Given this list of marker genes TAP1, STAT1, ANKRD22, GBP4, GBP1, WARS1, PSME2, CXCL9, AIM2, GBP5, here is a description of the gene set: studied in species Homo sapiens Human Gene Set: MATSUMIYA_PBMC_MODIFIED_VACCINIA_ANKARA_VACCINE_AGE_4_6MO_BCG_PRIMED_28DY_UP BACKGROUND: Tuberculosis (TB) remains a global health problem, with vaccination likely to be a necessary part of a successful control strategy. Results of the first Phase 2b efficacy trial of a candidate vaccine, MVA85A, evaluated in BCG-vaccinated infants were published last year. Although no improvement in efficacy above BCG alone was seen, cryopreserved samples from this trial provide an opportunity to study the immune response to vaccination in this population. METHODS: We investigated blood samples taken before vaccination (baseline) and one and 28 days post-vaccination with MVA85A or placebo (Candin). The IFN-gamma ELISpot assay was performed at baseline and on day 28 to quantify the adaptive response to Ag85A peptides. Gene expression analysis was performed at all three timepoints to identify early gene signatures predictive of the magnitude of the subsequent adaptive T cell response using the significance analysis of microarrays (SAM) statistical package and gene set enrichment analysis. RESULTS: One day post-MVA85A, there is an induction of inflammatory pathways compared to placebo samples. Modules associated with myeloid cells and inflammation pre- and one day post-MVA85A correlate with a higher IFN-gamma ELISpot response post-vaccination. By contrast, previous work done in UK adults shows early inflammation in this population is not associated with a strong T cell response but that induction of regulatory pathways inversely correlates with the magnitude of the T cell response. This may be indicative of important mechanistic differences in how T cell responses develop in these two populations following vaccination with MVA85A. CONCLUSION: The results suggest the capacity of MVA85A to induce a strong innate response is key to the initiation of an adaptive immune response in South African infants but induction of regulatory pathways may be more important in UK adults. Understanding differences in immune response to vaccination between populations is likely to be an important aspect of developing successful vaccines and vaccination strategies. TRIAL: ClinicalTrials.gov number NCT00953927. Genes up-regulated in peripheral blood mononuclear cell 28d vs 7d in infants (4-6m) (BCG-primed) after exposure to Modified Vaccinia Ankara (MVA) virus vaccine vector, time point 28D from publication Matsumiya M, Harris SA, Satti I, Stockdale L, Tanner R, O'Shea MK, Tameris M, Mahomed H, Hatherill M, Scriba TJ, Hanekom WA, McShane H, Fletcher HA (PMID 24912498)